The following is a description of a gene set: studied in species Mus musculus Mouse Gene Set: HALLMARK_MYC_TARGETS_V1 Mouse genes annotated to HALLMARK_MYC_TARGETS_V1 based on orthology mappings provided by the Alliance Genome Consortium from publication Howe DG, Blake JA, Bradford YM, Bult CJ, Calvi BR, Engel SR, Kadin JA, Kaufman TC, Kishore R, Laulederkind SJF, Lewis SE, Moxon SAT, Richardson JE, Smith C (PMID 30224793), and this is the list of marker genes: H2az1, Eprs1, Fbl, Vdac3, Snrpa, Pcbp1, Ssb, Cad, Mcm4, Psmd1, Snrpa1, Snrpb2 (NCBI Gene Id 80461), Ssbp1, Pa2g4, Eif3j1, Hnrnpu, Ndufab1, Apex1, Erh, Txnl4a, Prdx4, Snrpd1, Nolc1, Tra2b, Hnrnpd, Stard7, Psma4, Cul1, Cct7, Srsf7 (serine and arginine-rich splicing factor 7), Impdh2, Rrm1, Hnrnpa2b1, Hddc2, Glo1, Psmb2, Pabpc4, Pcna, Rpl14, Ube2e1, Nop16, Cdc20, Gspt1, Hspd1 (NCBI Gene Id 15510), Mrpl9, Npm1, Pwp1, Cstf2, Gm9531, Eif4a1, Eif4g2 (NCBI Gene Id 77989), Srm, Hdgf, Ap3s1, Tcp1, Phb1, Cct4, Kars1 (NCBI Gene Id 85305), Eef1b2, Cct2, Ppm1g, Rsl1d1, Pold2, Cct3, Psmd14, Ctps1, Usp1, Gnl3, Hnrnpr, Dek, Ranbp1, Rad23b, Prdx3, Iars1, Psmc4, Cyc1, Cdc45, Uba2, Trim28 (NCBI Gene Id 98191), Serbp1, Rpl22, Mad2l1 (MAD2 mitotic arrest deficient-like 1), Psmd8, Srsf1, Hnrnpc, Dhx15, Rpl18, Rps5, Hdac2, Syncrip, Xrcc6, Snrpd2, Nhp2, Phb2, Rfc4, Psmd7, Rnps1, Xpot, Rps2, Canx, Hprt1, Kpnb1, Eif2s2, Srsf2, Hnrnpa1, Cops5, Psmc6, Ruvbl2, Pgk1, Rps3, Ddx21, Pole3, Psmd3, Eif3b, Aimp2, Gm10146 (NCBI Gene Id 100505147), Psma6, Acp1, Cnbp, Rack1, Mcm7, Rps6, Sf3b3, Psma7, Cdk4, Vbp1, Mcm6, Ddx18 (DEAD box helicase 18), Cbx3, Sf3a1, Nme1, Rplp0 (ribosomal protein lateral stalk subunit P0), Rpl6, Lsm2, Ywhae, Abce1, Odc1, Srpk1, Ncbp1, Ccna2, Eif4h, Eif2s1, Tufm, C1qbp, Ncbp2, Rrp9, Gm4705, Psma1, Psmb3, Mrps18b, Snrpg, Ifrd1, Eif4e, Tardbp, Rps10, Ran, Smarcc1, Clns1a, Cct5, Exosc7, Prps2, Xpo1, Tyms, Psma2, Srsf3, Snrpd3, Ilf2, Ywhaq, Ldha, Tfdp1, Hspe1, Eif3d, Bub3, Gm10705, Cdk2, Etf1, Prpf31, Myc, G3bp1 (G3BP stress granule assembly factor 1), Ppia, Cox5a, Nop56, Orc2, Slc25a3, Vdac1, Mrpl23, Got2, Dut, Hsp90ab1, Mcm2, Tomm70a (NCBI Gene Id 70049), Nap1l1, Mcm5, Ptges3-ps, Hnrnpa3, Pabpc1, Fam120a